Given this list of marker genes YIPF1, RBM19, EYA3, EIF2S2, PLS3, CCL2, SEPHS2 (selenophosphate synthetase 2), CEP43, SLAMF1 (signaling lymphocytic activation molecule family member 1), GGPS1, LSR (lipolysis stimulated lipoprotein receptor), CD2, SEPHS1, HLTF, REST, LPL, XRCC4, PPP1CC, GLCE, MDFIC, ACOX1, ZNF177, NEK9, PDE8A, EXOSC9, ARB2A (ARB2 cotranscriptional regulator A), EPS8, LYZ, ZBTB18, POU2AF1, LYST, GPA33, GEMIN4, PRPF19, PALS2, AP2B1, GCFC2, MYCNOS, TAF2, ZNF273, ITM2A, TCAF1, ZNF266, NDUFB6, ID3, FLNB, VPS8, TUBGCP3, GPR65, CD6, ATM, PANX1, PKN2, DDX52, GTF3C2, PPBP, CCT6B, PRDX3, PDS5B, CXCL3, KHDC4, PDE3B, RGS16, ARHGAP11A, IRF9, DDX46, ABCA12, TNFRSF10B, MIOS, ZNF318, PPIE, CAD, CLPS, RGS10, PHYH, PLCB1 (phospholipase C beta 1), KLHL23, APOBEC3B, MYBPC2, GNG11 (NCBI Gene Id 2791), IGFBP4, STK38L, FEM1C, CLEC2B, SLCO2B1, ZBTB1, KCTD2, IFIT5, BMERB1, REL, SPAG5, ARID4B, WDR77, CLCN5, TMEM268, RB1, TBCE, B4GALT4, H4C13 (NCBI Gene Id 8368), GAPDH, PRCP, CD200 (CD200 molecule), BAG2, CSNK1D, MTSS1, SPP1, CSN3, SLC25A14, CCL20, SAPCD1, HMGB1, RHOH, ART3, KPNA1, PTK2B, MCM3AP (minichromosome maintenance complex component 3 associated protein), TRIM32, ARG2, CD27, VPS13D, ADSS2, TSN, SLC27A2, NINL, GRM1, ARL4D, JAK2, TCEAL1, RNASE2, COX7A1, PIGC, MAPK12, SNRPE, RASA1, EIF4A3, GEM, FBP2, ATF3, NEDD4, FABP5, UBXN2B, UBAC1, TGIF1, RECK, NR4A2, IGF2BP3, SERPINE2, RBFOX2, CCS, IFNGR1, FKTN, ZSCAN9, NPM1, CXCL2, GBP2, ZNF529, CLPX, ANAPC5, ALKBH1, RAB40B, RANBP6, ADGRE5, PLA2G7, OSGEP, ARHGAP29, HCP5, PPP1R2C, RLF, RND3, ZNF84, FAM53B, RPL21, PAPOLA, MDFI, TRAF1, POU6F1, SMC5, CD226, PI4K2A, TAF15, MED13L, MAP3K8, RFC4, RAB29, PSME2, RCBTB2, ASTN1, ACAT1, ABCG1, PAFAH2, DHRS3, IQGAP2, SCAMP1, CCN2, CD48, PEX3, CLCA2, PTPN22, ATP5ME, PTTG1, here is a description of the gene set: Genes down-regulated in dendritic cells: spleen CD8- versus brain. To understand the functional relationship between brain dendritic cells (brain DCs) and other myeloid cells, we compared the gene expression profile of m/chDCs to that of bone marrow monocytes, brain microglia and classical spleen CD8+ and CD8- DCs. In order to obtain enough brain DCs for mRNA extraction, we expanded brain DCs with in vivo Flt3L treatment before purification. species: Homo sapiens Human Gene Set: GSE29949_CD8_NEG_DC_SPLEEN_VS_DC_BRAIN_DN from publication Anandasabapathy N, Victora GD, Meredith M, Feder R, Dong B, Kluger C, Yao K, Dustin ML, Nussenzweig MC, Steinman RM, Liu K (PMID 21788405)